Given this list of marker genes Hapln4, Krt26, Arhgap33, Mtcl2, Plekhg4, Kdm7a, Ehf, Scamp4, Fam171a1, Limd2, Trim46, Muc5ac, Igf2, Acy3, Efna2, Tmc6 (transmembrane channel-like gene family 6), Bcl2l1, Taf7l2, Spock2, Map6, Gabrd, Zhx2, Yrdc, 2310011J03Rik, Tmem215, Lurap1, Inpp4a, Grb10, Naa80, Or51e1, Adcyap1r1, Hadha, Wnt4, Lin28a, Mrgprd, Zfp286, Ankzf1, Cdk5r1, Bcl2l11, Strn4, Bahcc1, Cbx2, Dusp18, Hao2, Pdzrn3, Immt, Add2, here is a description of the gene set: from publication Chen Y, Wang X (PMID 31504780) species: Mus musculus Genes predicted to be targets of miRBase v22 microRNA mmu_miR_3072_5p in miRDB v6.0 with MirTarget v4 prediction scores > 80 (high confidence targets). Mouse Gene Set: MIR_3072_5P